Given this list of marker genes DBI (diazepam binding inhibitor, acyl-CoA binding protein), FGF21, MDH1, SEC24D, INSIG1, LDLR, SEC23B, GPAM, INSIG2, KPNB1, PRKAA1, MBTPS2, AKT1, MTOR, SCARB1, SEC31A, FDFT1, SEC23A, INS, HMGCS1, RBP4, SP1, PPARGC1B, CYP51A1, MVD, NR1H2 (NCBI Gene Id 7376), MBTPS1, FDPS, FASN, SREBF2, SREBF1, PRKACA, CAMP, SAR1B, LPIN1, SQLE, PRKAG2, PRKAB2, SEC13, HMGCR, ATF6, SEC31B, PIK3CA, PRKAG3, IDI1, PPARG, SEC24B, SCAP, CDK8, NFYA, MIR33A, ACLY, SEC24A, SAR1A, YY1, AMFR, PRKAB1, LPL, SIRT1, GSK3A, SEC24C, MED15, MIR33B, PRKAA2, PRKAG1, SCD, ACSS1, CREB1, LSS, ACACA, RNF139, here is a description of the gene set: species: Homo sapiens Sterol regulatory element-binding proteins (SREBP) signaling Human Gene Set: WP_STEROL_REGULATORY_ELEMENTBINDING_PROTEINS_SREBP_SIGNALING